Given this list of marker genes PLEKHA5, DNM1, ALOX15, KRIT1, GRAMD2A, SYT5, HCN1, OBSCN (NCBI Gene Id 84033), HIP1R, MAPKAP1, SESTD1, RLBP1, TTPA, FRMPD4 (NCBI Gene Id 9758), ANXA2, GBF1, SNX20, WDR45, TULP3, TPCN1, COMMD1, SNX21, TWF2, AVIL, LAPTM4B, PLA2G4E, WASHC2C, AMER1, TTPAL, VILL, GSDME, VIL1, PLCZ1, PLEKHA4, MTSS2 (NCBI Gene Id 92154), TWF1, ADAP2, PLCD1, SYT1, LDLRAP1, SCIN, MARK1 (NCBI Gene Id 55887), KCNQ1, GSDMC (NCBI Gene Id 56169), SYT9, SDCBP2, RAG2, TRPM3, AMER3, SH3PXD2B, WIPI1, TPCN2, SH3PXD2A, PIRT, OSBPL2, PLCB1, PFN1, KCNJ1, CFL1, SNX3, ADAP1, PARD3, CHMP3, GSN, AMER2, ATP13A2, SYTL2, SDCBP, PHLDA3, SYT7, WIPI2, MYO1B, CLVS1, MYO1G, TULP1, CAPG, SNX14, GSDMD, HIP1, PLEK2, CLVS2, FCHO2, GSDMB, ANXA8 (NCBI Gene Id 653145), MAPT, PFN2, PICALM, SNAP91, SNX18, EXOC7, SNX5, DNM2 (dynamin 2), FLII, SYT10, ACTN2, JPH2, RPH3A, RAB35 (NCBI Gene Id 11021), KIF16B, EXOC1, GSDMA, WDR45B, KCNH1, DEFB4A, CGAS, FZD7, SLC9A1, TIRAP, SVIL, KCNJ2, KCNJ3, here is a description of the gene set: species: Homo sapiens Binding to phosphatidylinositol bisphosphate. Human Gene Set: GOMF_PHOSPHATIDYLINOSITOL_BISPHOSPHATE_BINDING